Given this list of marker genes Spaca3, Pglyrp4, Lyzl1, Lyz3, Lalba, Lyz1, Pglyrp2, Lyg2, Pglyrp3, Spaca5, Lyg1, Pglyrp1, Lyz2, Lyzl6, Lyzl4, here is a description of the gene set: species: Mus musculus Mouse Gene Set: GOMF_PEPTIDOGLYCAN_MURALYTIC_ACTIVITY A catalytic activity that contributes to the degradation of peptidoglycan.